Given this list of marker genes MMS19, KDM3B, POLA1, KATNA1, TTI1, CCT4, MZF1, BMS1, DDX18, SUCLA2, GTF2H3, CDC7, SGTA, ZMYM4, THOC2, MFN2, GTF2A2 (general transcription factor IIA subunit 2), USP14, GNL2, OARD1, PTPN7, AIMP1, TRIM27, TFAP4, RAP1A, SFSWAP, CTR9, GLMN, HMGN4, NFRKB, ACTL6A, METAP1, NKRF, GRB10, NUFIP1, HNRNPL, HDAC2, IFRD2, NDUFAF1, ANP32E, DDX39A, INTS10, VARS1, TPP2, CLPX, ZPR1, CSTF3, DNAJC7, NUP93, TAF2, IMMT, NUDT13, RUVBL1, PSMD3, CPSF4, MARS1, RTCA, DIMT1, CDK11A, COQ2 (NCBI Gene Id 27235), RANBP2, CEBPZ, CCNF, IDH3A, DDX46, CLP1, RFC1, PMS1, NUP62, EIF4E, NUP188, XPO6, DLAT, ABCF1 (ATP binding cassette subfamily F member 1), EIF5B, LANCL1 (NCBI Gene Id 10314), SEC63, NELFA, ANKRD17, AFG3L2, LARS2, PEX3, NXT2, EXTL2, BAHD1, here is a description of the gene set: species: Homo sapiens Neighborhood of EIF4E eukaryotic translation initiation factor 4E in the MORF expression compendium Neighborhood of EIF4E Human Gene Set: MORF_EIF4E